The following is a description of a gene set: Mutation-activated MET to PI3K signaling pathway. Pathway ID: N00044. Pathway type: Variant. Pathway class: nt06263 Hepatocellular carcinoma. Human Gene Set: KEGG_MEDICUS_VARIANT_MUTATION_ACTIVATED_MET_TO_PI3K_SIGNALING_PATHWAY Pathway Definition from KEGG: MET* -> GAB1 -> PI3K -> PIP3 -> AKT -| BAD species: Homo sapiens, and this is the list of marker genes: AKT1, PIK3CB, MET, PIK3CA, BAD, PIK3CD, AKT3, AKT2, GAB1